Given this list of marker genes Csf1r, Bmpr1a, Tmem119, Fgfr3, Actn3 (actinin alpha 3), Nfe2, Pkdcc, P2rx7, Pth, Notum, Bglap, Atp2b1, Rxrb, Ostn, Ltf, Smad3, Kl, Hif1a, Ccn1, Nell1, Gpm6b, Ltbp3, Mgp, Mia3, Mef2c, Ptn, Ccr1, Acvr2b, Acvr2a, S1pr1, Osr2, Srgn, Suv39h1, Fbn2, Isg15, Bglap2, Bmp4, Alox5, Rflnb, Rxra, Twist1, Wnt10b, Tfap2a, Trpm4, Phospho1, Ahsg, Bmpr1b, Asxl2, Ecm1, Acvr1, Bcor (BCL6 interacting corepressor), Bmp6, Comp, Vdr, Atraid, Gata1, Adrb2, Enpp1, Ank, Bmp2k, Ccr1l1, Gja1, Bmpr2, Bmp7, Ifitm5, Txlng (NCBI Gene Id 353170), Tent5a, Cyp27b1, Bmp2, Nbr1, Ano6, Ddr2, Sox9, Matn1, Fzd9, Ptk2b, Sgms2, Osr1, Slc8a1, Bglap3, Slc20a2, Grem1, Fgf23, Mepe, Rflna, Zmpste24, Fam20c, Wnt4, Cd276, Adgrv1, here is a description of the gene set: Mouse Gene Set: GOBP_REGULATION_OF_BONE_MINERALIZATION studied in species Mus musculus Any process that modulates the frequency, rate or extent of bone mineralization.